Given this list of marker genes Cadm3, Ang, Cdh4 (cadherin 4), Cdh9, Ctnnb1, Nectin3, Zeb2, Adam33, Nectin2, Pard6a, Ctnna1, Pard3, Pard6b, Cdh8, Pard6g, Cdh7, Cdh10, Nectin4, Cdh15, Cdh12, Cdh11, Cdh5, F11r (NCBI Gene Id 226655), Amot, Angptl4, Sdk2, Pvr, Actb, Cadm2 (NCBI Gene Id 72986), Afdn, Jup, Ilf3, Sdk1, Ctnnd1 (catenin delta 1), Cadm1, Hoxc8, Cdh13, Cdh17 (NCBI Gene Id 56487), Prkci, Cdh18, Sp1, Cdh3, Cdh6, Cdh2, Actg1, Adam19 (ADAM metallopeptidase domain 19), Nectin1, Cdh24, here is a description of the gene set: Mouse Gene Set: REACTOME_CELL_CELL_JUNCTION_ORGANIZATION species: Mus musculus Cell-cell junction organization